The following is a description of a gene set: Catalysis of the reaction: L-lysyl36- + 3 S-adenosyl-L-methionine = 3 H+ + N6,N6,N6-trimethyl-L-lysyl36- + 3 S-adenosyl-L-homocysteine. This reaction is the successive addition of three methyl groups to the lysine residue at position 36 of histone H3, producing histone H3K36me3. species: Homo sapiens Human Gene Set: GOMF_HISTONE_H3K36_TRIMETHYLTRANSFERASE_ACTIVITY, and this is the list of marker genes: PRDM9, SMYD5, NSD2, SETD2, ASH1L, SETD5